Given this list of marker genes Cbr3, Aifm2, Cbr1, Cbr1b, Ubiad1, Nqo1, Vkorc1l1, Cyp4f40, Ggcx, Vkorc1, here is a description of the gene set: studied in species Mus musculus The chemical reactions and pathways involving any of the forms of vitamin K, quinone-derived vitamins which are involved in the synthesis of blood-clotting factors in mammals. Vitamin K substances share a methylated naphthoquinone ring structure and vary in the aliphatic side chains attached to the molecule. Mouse Gene Set: GOBP_VITAMIN_K_METABOLIC_PROCESS